Given this list of marker genes RYR2, ANK2, SEC61G, TRAM1, GBF1, RTN4 (reticulon 4), ZFAND2B, SSR3, SEC61A2, RN7SL1, RN7SL3, KDELR3, VAPA, BHLHE40-AS1, RER1, AKT1 (AKT serine/threonine kinase 1), MIA3, PPP1R15A, SRP54, TRAM2, SEC16B, VPS54, YWHAE, RN7SL2, OS9, FKRP (fukutin related protein), SPCS1, GET1, STING1, SRP19, BAG6, SGTB, SRPRA, SRP14, SPCS3, MAN1A1, GJD2-DT, BCAP29, SEC61B, INSIG2, HSPA5, ZFAND2A, SRP68, SEC61A1, SEC62, GABARAPL2, SRP72, RAB3GAP1, CRYZL2P-SEC16B, SRP9, FREY1, BTF3, NACA, SEC16A, DDRGK1, TRAM1L1, CHMP4A, ENSG00000283175, UBAC2, SGTA, RAB3GAP2 (RAB3 GTPase activating non-catalytic protein subunit 2), PDIA2, BCAP31, CHMP4B, MIA2, KDELR1, HERPUD1, INSIG1, LRRK2, ANKRD13C, GPAA1, KDELR2, SEC63, GLP1R, SRPRB, RAB10, SPCS2, EDEM1, UBL4A (ubiquitin like 4A), SNAP25-AS1, TTC9-DT, GET4, here is a description of the gene set: A process in which a protein is transported to, or maintained in, a location within the endoplasmic reticulum. Human Gene Set: GOBP_PROTEIN_LOCALIZATION_TO_ENDOPLASMIC_RETICULUM species: Homo sapiens